Given this list of marker genes PUS10, EZH2, SRF, SRSF3, SMAD1, STAT3, DGCR8 (NCBI Gene Id 66034), DDX5, DROSHA, here is a description of the gene set: Human Gene Set: GOMF_PRIMARY_MIRNA_BINDING studied in species Homo sapiens Binding to a primary microRNA (pri-miRNA) transcript, an RNA molecule that is processed into a short hairpin-shaped structure called a pre-miRNA and finally into a functional miRNA. Both double-stranded and single-stranded regions of a pri-miRNA are required for binding.